Given this list of marker genes Vhl, Spns2, Hps1, Atp6ap2, Grk3, Ihh, here is a description of the gene set: Establishment of a pattern of pigment in the eye of an organism. Mouse Gene Set: GOBP_EYE_PIGMENTATION species: Mus musculus